The following is a description of a gene set: A protein complex that forms a transmembrane channel through which calcium ions may pass in response to changes in membrane potential. species: Mus musculus Mouse Gene Set: GOCC_VOLTAGE_GATED_CALCIUM_CHANNEL_COMPLEX, and this is the list of marker genes: Cacng4, Cacna2d4, Catsper3, Cacna2d2, Catsperz, C2cd6, Tmem262, Cacna2d3 (calcium channel, voltage-dependent, alpha2/delta subunit 3), Catsper2, Tmem249, Catsperd, Cacnb1, Catspere2, Cacna1s, Cacng1, Cacna1e, Efcab9, Cacna1c, Catsperg2, Cacna1b, Pde4d, Stac3, Cacng6, Catsper1, Hspa2, Cacng2, Slco6c1, Cacna1f, Catsper4, Catsperg1, Cacna1h, Cachd1, Cacna1a, Ryr1, Catspere1, Cacnb4 (calcium channel, voltage-dependent, beta 4 subunit), Cacng7, Cacnb3, Fkbp1a, Catsperb, Cacng8, Cacna1d, Cacnb2, Cacna2d1